The following is a description of a gene set: Mouse Gene Set: GOBP_DIACYLGLYCEROL_METABOLIC_PROCESS species: Mus musculus The chemical reactions and pathways involving diacylglycerol, a glyceride in which any two of the R groups (positions not specified) are acyl groups while the remaining R group can be either H or an alkyl group., and this is the list of marker genes: Pla2g15, Lipe, Ang2, Dgki, Dagla, Dgat2, Dgkb, Dgka, Plb1, Plce1, Dgke, Ang4, Apoa2, Ang6, Dgkk, Dgkd, Dgkz (diacylglycerol kinase zeta), Gpam, Ang, Avil, Pnpla2, Dgkg, Plpp1, Mogat2, Dgat1, Gpat4, Pgs1, Daglb, Dgkh, Ang5, Mogat1, Dgkq